Given this list of marker genes NFAT5, CRISPLD1, RFX3, SLC39A10, CEACAM7, TOMM70, FZD3, LANCL1, LIN52, MTF2, EMB, PIAS1, NARS2, FBXL17, NEXMIF, SLC26A7, HACE1, PIGT, ZNF302, PAPOLG, C1orf74, SRSF3, SINHCAF, PCGF5 (polycomb group ring finger 5), ITGBL1, PML, TMEM33 (transmembrane protein 33), CD302, DAZL, ARID1A, SCAI, GOLIM4, RBMS3, AGFG1, THSD7A, MIGA1, ZNF776, DPYS, RNF182, ST8SIA4, MOXD1, LCLAT1 (lysocardiolipin acyltransferase 1), NR4A3, MXRA7 (NCBI Gene Id 54588), DMC1, GPR88, PRKCB, ASXL3, MTFR2, ANGEL2, KCTD16, IGF2BP2, YY2, ATP10D, SLC35G1, PGRMC1, CLOCK, THAP5, AAK1, TTI1, GNS, SEPTIN7, CYTH3, LPP, ZBTB10, RPGRIP1L, MTSS1, LARP4, SLC30A4, HOOK1, TTC29, C5, CUX2, CRIM1 (cysteine rich transmembrane BMP regulator 1), ZMAT3, SP4, AVL9, NDST3, FMR1, CPT1A, KRT40, CUL3, PWWP3B, TSC1, CERK, DISC1, FBXW7, EFNB1, SPATA13, GRM3, KANSL3, PTGR3, MOB1B, TATDN3, SGK3, PTPN4, MOB4, FBN1, PLEKHM3, MIB1, SPARC, OSBPL8, CRKL, MFSD4A, RB1, ADGRG6, BANK1, MGAT4A, ZEB1, PUM2, CHAC2, ERICH3, METTL14, INSIG1, IPMK, IKZF5, PRKAR1B, PER2, BVES, ETNK1, LIN7C, LMBR1, PANK1, ANKS1A, SNX10, TMF1, FGF2, CNEP1R1, ITGB8, DSEL (NCBI Gene Id 92126), RALA, GRM5, ARHGAP29, PHF3, DGKH, MGA, UBR3, CEMIP, DENND5A, KCNA1, ZNF714, HRH4, EFNA5, ACTR2, SYT13, P4HA1, ANKRD12, TXLNG, CERS6, ADO, ABCA10, ZNF280B, IGDCC4, JCAD, ING3, BMP2, PPP1R2, SAMD8, PNPT1, LY75-CD302, RIC8A, PEX5L, PTPN14, BRPF1, MRE11, OXTR, ELAVL4, SAMHD1, DIXDC1, MOB1A, NUFIP2, HDAC9, WDR72, TMEM38B, ONECUT2, NUDT5 (NCBI Gene Id 11164), KLF6, ADAMTS5, GOPC, C11orf54, CAPZB, TRIM4, TAF5L, ACSL4, BICD2, RANBP3L, FOXN2, ZBTB18, CXCL11, GUCY1A2, TNF, RALGAPA2, SEMA3D, FUT9, RAB11A, FBXO42, ANKRD44, ONECUT1, PCSK5, CFAP97, MMGT1, MECP2, TRIM33, BEND3, BMPR1B, CSNK1G3, PJA2, ZFX, GJA3, ZNF507, LGALS8, DDX42, CMTM6, ICA1L, HSPA12A, TRIM2, NR1D2, PPTC7, STAG2, PCNA, EIF4A2, MEGF10, ZNF681, ANTXR1, MRPL35, CEP57L1, SRP9, BRD7, ARHGAP42, CLVS1, KLHL15, CCDC148 (NCBI Gene Id 130940), ATMIN, VRTN, SLC4A7, GDAP1, STAC3, DNAL1, NDFIP2, FAM114A2, METTL9, ADGB, PARP1, CXCL13, HOOK3, STAU2, LEPROT, HPRT1, SERAC1, C8orf44-SGK3, KCNMA1, FBF1, KAT6A, B3GNT5 (UDP-GlcNAc:betaGal beta-1,3-N-acetylglucosaminyltransferase 5), SRGAP1, GABRA4, CKAP5, ASPH, FSHB, ZNF678, CC2D1B, RLN2, ZFP36L2, here is a description of the gene set: from publication Chen Y, Wang X (PMID 31504780) Human Gene Set: MIR4263 studied in species Homo sapiens Genes predicted to be targets of miRBase v22 microRNA hsa-miR-4263 in miRDB v6.0 with MirTarget v4 prediction scores > 80 (high confidence targets).